Given this list of marker genes IPCEF1, GOLM1, ANXA3, BCL3 (NCBI Gene Id 602), LAD1, NFKB1, PSME2, CPXM2, CAPG, ADGRG5, TSPAN9, GM2A, TIAM1, WFDC2, SEMA4F, MCF2L, BNIP5, KRT77, ACACB, LRRK1, PRMT2, ITM2C (NCBI Gene Id 9523), SERPINC1, REG3A, CRHBP, CD82, ITGAE, AEBP2, TRAF3, MFSD4A, S100A14, PLB1, SAA2, GBP4, FOXA1, SCAMP2, HTR7, PRR13, CEMIP2, RIGI, S100A16, PMEPA1, IZUMO1R, DIO1, GRAMD1A, FOS, CYP2F1, TLR1, MYO1G, ZMIZ2, BATF3 (basic leucine zipper ATF-like transcription factor 3), TFAP2B, BLNK, CRP, SLFN13, SWAP70, OASL, TRIM25, BGN, CCL5, NSMF, SPECC1, CDCP1, ATP1B3, ADAMTS9, CNN2, TRIM7, TMEM63A, LTB, ROGDI, BCL2L15, CACNB3, LARP6, KBTBD11, SAMHD1, ENO3, HPS4, GRB10, STAT6, ATP1A2, CTSH, OLFM1, C1R, WFIKKN2, NUDT17, GNG2, CD40, DAPL1, IER5, CHST15, FOSL2, CCND1, SPP1, ZC3H12D, BTLA, SERPINB1, IL11RA, ANXA10, TMEM51, GUSB, SMPDL3A, SLC22A23, ARG2, HLA-DRB1, COTL1, COL4A2 (collagen type IV alpha 2 chain), ECM1, NEK6, CCL17, STING1, FZD2, C3, ITGB7, TIMP1, SH3PXD2B, RUNX3, SEMA4A, KIAA1614, SFRP1, HLA-G, HLA-DMA, IGFBP7, TOR3A, PARP9, MICALL1, CISH, FOXO1, AFDN, PLEK, GDA, TMEM158, MX2, HSPB1, AVIL, IL13RA2, CLDN7, TNMD, SELENOM, ST6GAL1, XAF1, CDHR1, CD72, BCL2, SPINT1, GALNT6, SHISA4, KLF2, SYT1 (NCBI Gene Id 6857), RGS4, IRF1, TCAF2, PENK, INF2, N4BP2L1, TPM2, TNFRSF1B, HDC, ADM, RASA3, SH3TC2, CSF2RB, GJA4, HAL, NOSTRIN, LPO, LY6H, PCP4, APLP2, ITPRIPL2, WDFY4, EMP2, RSAD2, MSC, ITGB5, MISP, NKG7, CCR6, DUSP5, LYPD2, NFATC2, SOSTDC1, NREP, RRBP1, MTARC1, HLA-B, PDLIM4, STX7, EEIG1, PARP3, IFITM3, NLRC5, SUSD6, DAP (death associated protein), TBC1D4, PDCD1LG2, NAPSA, UBD, DHX58, SERPINB12, GPR18, here is a description of the gene set: studied in species Homo sapiens Polymorphonuclear leukocytes (PMNs) were obtained from healthy individuals in accordance with protocols approved by the Institutional Review Board for Human Subjects at the University of Minnesota and the National Institute of Allergy and Infectious Diseases. PMNs (107) were combined on ice with live S. aureus (108) or with live or heat-killed A. phagocytophilum (bacteria isolated from 5x106 infected HL60 cells for a ratio of 1 infected HL60 cell: 2 PMNs, ~ 5-20 A. phagocytophilum: PMN) in wells of a 12-well tissue culture plate (pre-coated with 20% autologous normal human serum). Unstimulated control assays received either buffer (for S. aureus comparisons) or clarified HL60 lysate (for A. phagocytophilum comparisons). Plates were centrifuged at 350 x g for 8 min at 4oC to synchronize phagocytosis and incubated at 37 deg. C in a CO2 incubator for the indicated times. At the indicated times, tissue culture medium was aspirated from the plate and PMNs were lysed directly with RLT buffer (Qiagen, Valencia, CA). Purification of PMN RNA and subsequent preparation of labeled cRNA target was performed as described in Methods. Labeling of samples, hybridization of cRNA with HU133A oligonucleotide arrays (Affymetrix, Santa Clara, CA), and scanning were performed according to standard Affymetrix protocols ( http://www.affymetrix.com/pdf/expression_manual.pdf ). Experiments were performed in triplicate, using PMNs from three healthy individuals for each treatment. Human Gene Set: GSE2405_S_AUREUS_VS_A_PHAGOCYTOPHILUM_NEUTROPHIL_UP from publication Borjesson DL, Kobayashi SD, Whitney AR, Voyich JM, Argue CM, Deleo FR (PMID 15879137) Genes up-regulated in polymorphonuclear leukocytes 9h after infection by: S. aureus versus A. phagocytophilum.